Given this list of marker genes ATR, CCNB1, WEE1, CCNB3, CHEK1, CCNB2 (cyclin B2), CDK1, here is a description of the gene set: Human Gene Set: KEGG_MEDICUS_REFERENCE_WEE1_CELL_CYCLE_G2_M WEE1-Cell cycle G2/M. Pathway ID: N00459. Pathway type: Reference. Pathway class: nt06161 Human immunodeficiency virus 1 (HIV-1). studied in species Homo sapiens Pathway Definition from KEGG: ATR -> CHEK1 -> WEE1 -| (CCNB+CDK1)